Given this list of marker genes Dync1h1, Bnc2, Flt1, Alg6, Micos13, Slc18b1, Fmn1, Metap2, Tnfaip3, Gpr35, Plek, Il1b, Nbas, Atp13a2, Ccl3, Abcf1, Ccdc13, Cd3e, Hsf4, Il6st, Sh3tc2, Tnfaip2, Hvcn1, Mapre1, Fam53b, Pakap, Trem1, Strap, Sh2d2a, Glrb, Ino80b, Dennd4a, Msmo1, Cpeb2, Slamf7, Sox10, Dock2, L3mbtl1, Dip2b, Meis2, Cltc, Nfkbiz (nuclear factor of kappa light polypeptide gene enhancer in B cells inhibitor, zeta), Dlat, Col4a1, Rgs1, Gtf2h4, Il1r2, Ptafr, Cimap1c, Trim69, Dclk2, Ccr5, Cd300a, Inpp4b, Tsen2, Paqr6, Cd3d, Il10, Ezh2, Cyp39a1, Krtdap, Nlrp3, Ttc23, Scly, Tom1, Sectm1a, Snx25, Ndufa3, Fosb, Klf6, Lrrc27, Clec4d, Sdhc, Slc15a3, Nat8 (N-acetyltransferase 8 (GCN5-related)), Atp6v1c1, Ndufs1, Nfkbid, Brca1, Zeb2, Mmrn2, Cxcl1, Tnf (NCBI Gene Id 21926), Farsb, Ebf1, Sh3bp5, Klf4, Malt1, Syt9, Cnot2, Ppt2, Hyal1, Dhtkd1, Lgals3, Adam8, Cbl, Wbp11, Slc7a11, Telo2, Ephx1, Rnd1, Il1a, Tspan6, Rasgef1b, Tacc1, Chchd10, Slc11a1, Lrrc47, Ccl4, Eif3l, Lpcat2, Psmc3, Eif4g2, Dok2, Csrnp1, Phb2, Ctla4 (NCBI Gene Id 12477), Smap1, Plxnc1, Slc12a7, Slc23a2, Pkib, Lilrb4b, Hbb-bs, Hcar2, Hlf, Psph, Mindy3, Tfpt, Eogt, Ivd (isovaleryl coenzyme A dehydrogenase), Huwe1, Cd83, Rusc2, Nfkbia, Gpr132 (G protein-coupled receptor 132), Amfr, Kif21a, Rac2, Fabp7, Oxnad1, Trpv2, Rel, Marco, Ppp1r7, Cxcl2, Rnf157, Ran, Ss18l2, Zcrb1, Acod1, Mlph, Plin3, Aire, Lsmem1, Ubc, Syne2, Xrn2, Hnrnpr, Gpr137b, Cxcl3, Il6, Adamtsl4, Shroom1, Fuom, Clec4e, Il7r, Il1rn, Dusp1, Slc44a3, Sub1, Ccr7, Psme2, Sppl2b, Map7d2, Elk4, P2ry10, Lcp2, Stap1, Wdfy4, Nat9, Zfp993, Osm, Adgrf5, Rasd2, Actb, Gpr21, Acot2, Atp1a1, Slc2a6, Hmgcr, Ccrl2, F10, Trub2, Gla, Erlin2, Slc30a7, Per1, L3mbtl2, Eid3, here is a description of the gene set: from publication Zeng Z, Gu SS, Wong CJ, Yang L, Ouardaoui N, Li D, Zhang W, Brown M, Liu XS (PMID 36240281) species: Mus musculus Metagene derived from the control samples, found to be predictive of immune checkpoint blockade treatment response, not otherwise discussed. Mouse Gene Set: ZENG_GU_ICB_CONTROL_METAGENE_44_PRECICTIVE_ICB_RESPONSE Most patients with cancer are refractory to immune checkpoint blockade (ICB) therapy, and proper patient stratification remains an open question. Primary patient data suffer from high heterogeneity, low accessibility, and lack of proper controls. In contrast, syngeneic mouse tumor models enable controlled experiments with ICB treatments. Using transcriptomic and experimental variables from >700 ICB-treated/control syngeneic mouse tumors, developed a machine learning framework to model tumor immunity and identify factors influencing ICB response. Projected on human immunotherapy trial data, found that the model can predict clinical ICB response. further applied the model to predicting ICB-responsive/resistant cancer types in The Cancer Genome Atlas, which agreed well with existing clinical reports.